The following is a description of a gene set: The directed movement of calcium ions (Ca2+) into the cytosol. Human Gene Set: GOBP_CALCIUM_ION_TRANSPORT_INTO_CYTOSOL species: Homo sapiens, and this is the list of marker genes: CACNA1C, P2RX7, ASPH, P2RX2, SLC8A1, TRPC3, P2RX5, JPH2, GRIN1, CACNA2D1, PLA2G1B, TRPV5, PML, BCL2, JPH4, ADCYAP1R1, JPH1, CACNB3, BAK1, RYR2 (NCBI Gene Id 6262), JPH3, SLC8A3, EPO, TMBIM6, CD4, P2RX4, NOS1, BAX, P2RX3, CAV1, CALCA